Given this list of marker genes Apc2, Ezh2, Mmut, Prtn3, Arhgef19, Ralbp1, Ccdc125, Mapre2, Lars1, Tax1bp3, Ccl24, Dock11, Ccl11 (C-C motif chemokine ligand 11), Rapgef1, Usp6nl, Foxj1, Dock10, Tbc1d20, Rgs14, Itga6, Rab11fip2, Prex1, Dock7, Tbc1d30, Wdr41, Map4k4, Myo9b, Rsu1, Nf1, Fermt2, Ndel1, Rap1gap, Plxnb1, Ntf3, Nedd9, Arhgef10, Ccr7, Rtn4r, Arhgef7, S100a10, Grhl3, Rgs6, Rgma (repulsive guidance molecule family member A), Tbc1d2, C9orf72, Rcc2, Rgs16, Snx9 (sorting nexin 9), Dock8, F2r, Scrib, Srgap2, Arhgap24 (NCBI Gene Id 75397), Rasgrp1, Ntrk3, Rgp1, Sema4d, Rgs8, Arhgef5, Gsk3b, Rack1, Dennd1b, Pip5k1a, Tbc1d7 (TBC1 domain family, member 7), Epha1, Akt2, Gnb5, Evi5, Rhog, Asap3, Dvl2, Evi5l, Sgsm2, Syde1, Tgm2 (transglutaminase 2, C polypeptide), Rasgrf1, Snx13, Odam (odontogenic, ameloblast asssociated), Sipa1l1, Bcar3, Arhgef16, Arhgap35, Dock9, Thy1, Gpr65, Epha2, Dvl3, Arhgap6, Crkl, Lims1, Rap1a, Mtss2, Rapgef3, Adcyap1, Usp17le, Rab3gap1, Ric1, Agrn, Ptk2b, Als2, Kalrn, Slc27a4, Rasgrp2, Arap1, Cd40, Rgs1, Dennd1a, Vav1, Hras, Cxcl13, Rgs10, Ect2, Wnt4, Smcr8, Arhgap42, Abr, Rapgef2, Wnt11, Net1, Rapgef6, Ntrk1, Ccl19, Pin1, Cav2, Wnt5a, Tiam1, Ralgapa1, Ralgapa2, Bcr, Arhgap11a (NCBI Gene Id 228482), Mex3b, Tsc1, Rgs7, Pkp4, Ralgapb, Snx18, Zc3h15, Crk (v-crk avian sarcoma virus CT10 oncogene homolog), Sgsm3, Rangap1, Pin1rt1, Sh3bp1, Ccl26, Itgb1, F2rl1, Coro1c, here is a description of the gene set: Mouse Gene Set: GOBP_POSITIVE_REGULATION_OF_GTPASE_ACTIVITY Any process that activates or increases the activity of a GTPase. species: Mus musculus